The following is a description of a gene set: Catalysis of the removal of a methyl group from a di or a monomethyl-lysine residue at position 9 of the histone H3 protein. This is a dioxygenase reaction that is dependent on Fe(II) and 2-oxoglutarate. Mouse Gene Set: GOMF_HISTONE_H3K9ME_H3K9ME2_DEMETHYLASE_ACTIVITY studied in species Mus musculus, and this is the list of marker genes: Kdm7a, Kdm3b, Phf8, Hr, Kdm3a